Given this list of marker genes Gna14, Marcks, Prkca, Plcb3, here is a description of the gene set: electronically inferred by orthology from the curated human pathway studied in species Mus musculus This event has been computationally inferred from an event that has been demonstrated in another species.<p>The inference is based on the homology mapping from PANTHER. Briefly, reactions for which all involved PhysicalEntities (in input, output and catalyst) have a mapped orthologue/paralogue (for complexes at least 75% of components must have a mapping) are inferred to the other species. part of: Regulation of insulin secretion Reactome Pathway: Acetylcholine regulates insulin secretion